Given this list of marker genes HBB, PKLR, ABCG8 (ATP binding cassette subfamily G member 8), NHLRC2, SPTB, TPI1, here is a description of the gene set: species: Homo sapiens Chronic hemolytic anemia Human Gene Set: HP_CHRONIC_HEMOLYTIC_ANEMIA An chronic form of hemolytic anemia.